Given this list of marker genes Pik3c3, Ppp2r5a, Arhgap45, Rhot2, Tubb4b, Mad2l1, Aaas, Rtkn (NCBI Gene Id 20166), Actr2, Ywhah, Rhpn1, Rhob, Dvl1, Wasf3, Baiap2l2, Ndc80, Tubb4a, Tubb2b, Fgd1, Ppp2r5d, Calm1, Nudc, Ppp2r5b, Pak6 (NCBI Gene Id 214230), Cpd, Dock8, Evl, Cenpn, Pak4, Esyt1, Slitrk3, Rhoh, Itsn1, Gopc, Nf2, Arhgap28, Men1, Ddx4, Muc13, Csk, Sos2, Kif2b, Ckap4, Fgd2, Flot2, Cdc25c, Dlg4, Plk1, Arpc2, Cyba, Tpm3, Rbmx, Stard8, Vrk2, Pcdh7, Rab7, Fam169a, Akap12, Spc24, Vim, Ndufa5, Myh10, Plin3, Samm50, Dock2, Zwilch, Rab9b, Myl6, Arhgap11a, Ndufs3, Mrtfa, Acbd5, B9d2, Plekhg6, Sfn, Myl9, Frs2, Arhgap17, Arhgap19, Trip10, Sema4f, Ar, Arhgap42, Clasp1, Atp6ap1, Fam13b, Lamtor1, Mis12, Pld2, Plekhg3, Vangl2 (NCBI Gene Id 93840), Twf1, Rac3, Lin7b, Scfd1, Arhgap40, Cct7, Pik3r2, Tor1aip1, Lbr, Nde1, Arhgef7, Tuba1a, Vhl, Arhgef10l, Ckb, Ywhae, Ncf2, Baiap2l1, Arhgap12, Ubxn11, Kntc1, Arpc4, Arhgef1, Fam83b, Stard13, Pfn1, Mfn2, Cyfip2 (NCBI Gene Id 76884), Armcx3, Arpc5, Rnd1, Tuba1b, Tagap, Xpo1, Lrrc1, Epha2, Aurkb, Arhgap8, Msi2 (musashi RNA-binding protein 2), Tuba4a, Nsfl1c, Arhgap44, Arhgap25, Ophn1, Mapk14, Arhgap18, Wwp2 (NCBI Gene Id 66894), Nox3, Arap1, Vav1 (NCBI Gene Id 22324), Dnmbp, Ppp2r1b, Wasf1, Mapk11, Rnd2 (NCBI Gene Id 11858), Pde5a, Dlc1, Cdc37, Itgb3bp, Arhgef12, Tuba1c, Nup133, Rhov, Ocrl, Arhgap9, Arhgef10, Swap70, Gmip, Mcam, Dynll1, Gja1, Cdh1, Htr7, Rhoj, Cct2, Vcp, Mtmr1, Dock5, Tuba8, Farp1, Noxa1, Uaca, Cdc42, Arhgap10, Cenpq, Arhgef17, Wdr6 (WD repeat domain 6), Pkn1, Ccdc187, Pgrmc2, Ptk2, Faf2, Jup, Dvl2, Ncf1, Noxo1, Gna13, Ankle2, Letm1, Nckipsd, Dsg1a, Prkca, Emc3, Pdpk1, Mad1l1 (MAD1 mitotic arrest deficient 1-like 1), Lmnb1, Actc1 (NCBI Gene Id 11464), Dync1li2, Arhgap33, Cct6a, Lck, Myo19, Rac2 (Rac family small GTPase 2), Kif2c, Zfp512b, Fmnl2, Dvl3, Klc3, Cenpu, Kidins220, Tubb6, Actr3, Fgd5, Hmox2, Vangl1, Arhgap22, Emd, Rhou, Fam13a, Arhgap15 (Rho GTPase activating protein 15), Myh14, Cav1, Ska1, Arhgdib, Arhgef15, Prex1, Hspe1, Grb2, Seh1l, Tmod3 (tropomodulin 3), Nup85, Steap3, Ccne1, Picalm, Gfod1, Arhgdig, Ccdc115, Ktn1 (NCBI Gene Id 16709), Flot1, Plxnd1, Cenpm, Fermt2, Ndel1, Tnfaip1, Bcap31, Tuba3b, Cenps, Racgap1, Dock11, Pak3, Trak1, Mpp7, Tubal3, Ctnnb1, Diaph2, Arhgef3, Klc4, Ngef, Cenpt, Slitrk5, Spen, Arhgef39, Lman1, Basp1, Cenpe, Stk10, Stam, Mapk3, Arhgap26 (Rho GTPase activating protein 26), Sh3bp1, Pfn2, Depdc1b, Ptpn13, Tmem87a, Ppp1r14a, Txnl1, Kif5b, Cenpa, here is a description of the gene set: Reactome Pathway: Signaling by Rho GTPases, Miro GTPases and RHOBTB3 part of: Signal Transduction This event has been computationally inferred from an event that has been demonstrated in another species.<p>The inference is based on the homology mapping from PANTHER. Briefly, reactions for which all involved PhysicalEntities (in input, output and catalyst) have a mapped orthologue/paralogue (for complexes at least 75% of components must have a mapping) are inferred to the other species. species: Mus musculus electronically inferred by orthology from the curated human pathway